Given this list of marker genes ABCB1, ABCA7, ATP8A2, ABCA1, ABCG1, ATP8A1, ABCA2, ABCB4, ATP8B3, ATP8B1, ATP10A, ATP11A, ATP8B2, ATP11C, RFT1, ATP11B, here is a description of the gene set: Human Gene Set: GOMF_FLOPPASE_ACTIVITY species: Homo sapiens Catalysis of the movement of a lipid from the cytosolic to the exoplasmic leaflet of a membrane, using energy from the hydrolysis of ATP.